The following is a description of a gene set: Genes predicted to be targets of miRBase v22 microRNA mmu_miR_5622_3p in miRDB v6.0 with MirTarget v4 prediction scores > 80 (high confidence targets). studied in species Mus musculus Mouse Gene Set: MIR_5622_3P from publication Chen Y, Wang X (PMID 31504780), and this is the list of marker genes: Bmp5, Rrm1, Rfx4, Zcchc24, Plekha1, Cxxc4, Mex3d, Zfp800, Slc39a10 (solute carrier family 39 (zinc transporter), member 10), Hpcal4, Jmjd1c, Adnp, Npsr1, Kctd9, Zgrf1, Bhlhe23, Nsun5, Meioc, Stag2, Socs6, Tmem170b, Trmt44, Lrp12, Tmeff1, Cebpd, Tbx20, Grpel1, Rab5a, Fgfbp3, Tafa5, Arrb1, Lrp11, Syap1, Gpd1l, Esr1, Sim1, Rabgap1l, Trappc2, Bptf, B3glct, Man1a, Cdk5rap2, Mob1a, Lhfpl3, Capn13, Tcf12, Elovl6, F2r, Spry2, Trpm5, Rps6ka6, Scn3a, Prox2, Tmem33, Acad8, Nat2, Selenoi, Nipbl, Mtpn